The following is a description of a gene set: Mouse Gene Set: GOBP_POSITIVE_REGULATION_OF_CHROMOSOME_CONDENSATION studied in species Mus musculus Any process that activates or increases the frequency, rate or extent of chromosome condensation., and this is the list of marker genes: Ncapg (NCBI Gene Id 70636), Smc2, Ncapg2, Ncaph2, Smc4, Ncaph, Ncapd3, Ncapd2